The following is a description of a gene set: species: Homo sapiens The process in which a myeloid precursor cell acquires specializes features of a megakaryocyte. Human Gene Set: GOBP_MEGAKARYOCYTE_DIFFERENTIATION, and this is the list of marker genes: ZFPM1, PF4, VPS33B, CDKN2B, FAXDC2, H4C15, WASF2, H4C13, IL11, H4C6, GATA2, PITHD1, RAB7B, TESC, L3MBTL1 (L3MBTL histone methyl-lysine binding protein 1), FLNA, TAL1, SP3, GP1BA, RCOR1, BLVRB, HMGB2, GABPA, H4C16, KIT, H4C14, MEIS1, H4C9, PRMT1, ZNF385A, SH2B3, MAF, PIP4K2A, H4C2, PTPN11, PRMT6, RBM15, THPO, MED1, FLI1, MYB, SCIN, MTURN, GP9 (NCBI Gene Id 2815), ABI1 (abl interactor 1), ZNF16, EP300, EIF6, H4C11 (NCBI Gene Id 8363), MPIG6B, H4C4, MEF2C, CNOT4, H4C1, LOX, MIR486-1, GP1BB, H4C3, H4C5, H4C8, SRF, CIB1, H4C12, UBA5, GP5 (glycoprotein V platelet), GATA1, PTPN6